Given this list of marker genes ATOX1, IPCEF1, HHEX, CDKN2D, MBP, NQO1, TXN, LSP1, EGLN2 (egl-9 family hypoxia inducible factor 2), TXNRD2, FTL, SOD1, GCLM, PRDX4, NDUFA6, MSRA, GLRX, NDUFB4, NDUFS2, PTPA, PRNP, G6PD, MGST1, SRXN1, LAMTOR5, HMOX2 (heme oxygenase 2), SBNO2, PRDX1, CAT, PDLIM1, OXSR1, ERCC2, PRDX2, SOD2 (superoxide dismutase 2), GSR, GPX4, PFKP, SELENOS (selenoprotein S), GPX3, PRDX6, ABCC1, STK25, FES, SCAF4, JUNB, GLRX2, TXNRD1, MPO (NCBI Gene Id 4353), GCLC, here is a description of the gene set: Genes up-regulated by reactive oxigen species (ROS). Human Gene Set: HALLMARK_REACTIVE_OXYGEN_SPECIES_PATHWAY from publication Liberzon A, Birger C, Thorvaldsdóttir H, Ghandi M, Mesirov JP, Tamayo P (PMID 26771021) studied in species Homo sapiens